The following is a description of a gene set: Genes predicted to be targets of miRBase v22 microRNA mmu_miR_7653_3p in miRDB v6.0 with MirTarget v4 prediction scores > 80 (high confidence targets). Mouse Gene Set: MIR_7653_3P from publication Chen Y, Wang X (PMID 31504780) studied in species Mus musculus, and this is the list of marker genes: Jph1, Sumo2, Mga, Ehf, Alkbh7, Rnf170, Ppp1r3a, Fibcd1, Sirt6, Srcap, Ttc38 (NCBI Gene Id 239570), Fam180a (NCBI Gene Id 208164), Klhl8, Zfp655, Sulf1